Given this list of marker genes ATL1, RTN3, REEP4, RAB18, LNPK, REEP2, RAB3GAP1, ARL6IP1, ATL2, RTN2, RAB10, RAB3GAP2, ZFYVE27, TMEM170A, REEP1 (receptor accessory protein 1), ATL3, TMEM33, RETREG3, RTN4, USE1, DMTN, RTN1, REEP3, here is a description of the gene set: species: Homo sapiens A process that is carried out at the cellular level which results in the assembly, arrangement of constituent parts, or disassembly of the endoplasmic reticulum (ER) tubular network. The ER tubular network is the ER part that that has membranes with high curvature in cross-section. Human Gene Set: GOBP_ENDOPLASMIC_RETICULUM_TUBULAR_NETWORK_ORGANIZATION